Given this list of marker genes Madcam1, Dock8, Il4, Ptk2b, Coro1a, Itgb3, Aif1, BC037156, Med23 (mediator complex subunit 23), Tnfsf14, Tnfrsf14, Stk39, Ccl20, Lgals9, Rhoa, Cxcl10, Nedd9, Wnt5a, Pycard, Abl2, Ccr2, Tmem102, Ccl21a, Selenok, Tnfsf4, Spn, Jam2, Ccr7, Ascl2, Adam10, Wnk1, Ccl5, P4hb, Itga4, Cd99l2, Adam17, Xcl1, App, Abl1, Ccl3, Ccl7, Adam8, Fadd, Cxcl12, Cxcl14, Cxcl13, Oxsr1, here is a description of the gene set: studied in species Mus musculus Any process that activates or increases the frequency, rate or extent of lymphocyte migration. Mouse Gene Set: GOBP_POSITIVE_REGULATION_OF_LYMPHOCYTE_MIGRATION